The following is a description of a gene set: species: Mus musculus Mouse Gene Set: GOBP_CELLULAR_RESPONSE_TO_CHOLESTEROL Any process that results in a change in state or activity of a cell (in terms of movement, secretion, enzyme production, gene expression, etc.) as a result of a cholesterol stimulus., and this is the list of marker genes: Ces1h, Gpld1 (glycosylphosphatidylinositol specific phospholipase D1), Ptch1, Gramd1b, Lrp6, Ces1d, Cyp7a1, Ces1e, Ces1a, Ces1b, Gramd1a, Dag1, Lrp8, Ces1g, Ces1f (carboxylesterase 1F), Gramd1c, Nfe2l1, Smo, Inhbb, Gpr155, Osbpl7, Abca1, Inhba, Ces1c, Mlc1